Given this list of marker genes UBE2J1, ERLEC1, OS9, DERL2, DERL3, UBE2G2, INSIG1, UBAC2, SVIP, YOD1, here is a description of the gene set: Any process that stops, prevents, or reduces the frequency, rate or extent of the directed movement of proteins from the endoplasmic reticulum. Human Gene Set: GOBP_NEGATIVE_REGULATION_OF_PROTEIN_EXIT_FROM_ENDOPLASMIC_RETICULUM studied in species Homo sapiens